Given this list of marker genes CNTN2, DRD1, FEZF2, LHX6, DRD2, ARX, here is a description of the gene set: species: Homo sapiens Human Gene Set: GOBP_CEREBRAL_CORTEX_GABAERGIC_INTERNEURON_MIGRATION The migration of GABAergic interneuron precursors from the subpallium to the cerebral cortex.